The following is a description of a gene set: Reactome Pathway: Nucleotide salvage part of: Metabolism of nucleotides Nucleosides and free bases generated by RNA and DNA breakdown are converted back to nucleotide monophosphates, allowing them to re-enter the pathways of nucleotide biosynthesis and interconversion. Under normal conditions, DNA turnover is limited and deoxyribonucleotide salvage operates at a correspondingly low level. species: Homo sapiens, and this is the list of marker genes: AMPD2, GMPR2, HPRT1, DGUOK, MAPDA, GMPR, PUDP, TYMP, AMPD1, UCK1, ADA, DCK, TK1, APRT (NCBI Gene Id 353), UCK2, CDA (NCBI Gene Id 978), UCKL1, AMPD3, ADK, UPP1 (NCBI Gene Id 7378), PNP, TK2, UPP2